The following is a description of a gene set: Human Gene Set: GOBP_REGULATION_OF_MRNA_3_END_PROCESSING studied in species Homo sapiens Any process that modulates the frequency, rate or extent of mRNA 3'-end processing, any process involved in forming the mature 3' end of an mRNA molecule., and this is the list of marker genes: NCBP2, BARD1, NCBP1, CPEB1, ZFP36L1, CDC73, AHCYL1, DHX36, CDK9, CCNB1